Given this list of marker genes GRB2, FGF2, FGF17 (fibroblast growth factor 17), FGF3, FGF20, FGF22, FGF10, FGF4, FGF23, KRAS, FGF1 (NCBI Gene Id 29961), FGF5, KL, FGF6, SHC1, HRAS, NRAS, FGF9, FGF8, FGFR1, SOS1 (SOS Ras/Rac guanine nucleotide exchange factor 1), here is a description of the gene set: Human Gene Set: REACTOME_SHC_MEDIATED_CASCADE_FGFR1 studied in species Homo sapiens SHC-mediated cascade:FGFR1